Given this list of marker genes Pck1, Lep, Pgp, Got1, Pck2, here is a description of the gene set: The chemical reactions and pathways resulting in the formation of glycerol, 1,2,3-propanetriol, a sweet, hygroscopic, viscous liquid, widely distributed in nature as a constituent of many lipids. Mouse Gene Set: GOBP_GLYCEROL_BIOSYNTHETIC_PROCESS species: Mus musculus